The following is a description of a gene set: species: Mus musculus This event has been computationally inferred from an event that has been demonstrated in another species.<p>The inference is based on the homology mapping from PANTHER. Briefly, reactions for which all involved PhysicalEntities (in input, output and catalyst) have a mapped orthologue/paralogue (for complexes at least 75% of components must have a mapping) are inferred to the other species. electronically inferred by orthology from the curated human pathway Reactome Pathway: Downstream signaling events of B Cell Receptor (BCR) part of: Signaling by the B Cell Receptor (BCR), and this is the list of marker genes: Nfkbib (nuclear factor of kappa light polypeptide gene enhancer in B cells inhibitor, beta), Malt1, Nfkb1, Psmc6, Psma6, Psmb5, Cul1, Psma3, Psma1, Ppp3r1, Rps27a, Psmd1, Nfkbie (nuclear factor of kappa light polypeptide gene enhancer in B cells inhibitor, epsilon), Psmb7, Nfkbia, Psmc5, Rasgrp1, Ubb, Calm1, Hras, Psma7, Psmc1, Psmc2, Psmc3, Psmd7, Psmd12, Psmc4, Fkbp1a (FK506 binding protein 1a), Psmb4, Rela, Psmd6, Rasgrp3 (RAS, guanyl releasing protein 3), Psmb6, Psmd13, Psma5, Ikbkb, Psma4, Psma2